The following is a description of a gene set: species: Homo sapiens Genes down-regulated in peripheral blood mononuclear cell 192h vs 0h in adults (22-54) after exposure to F. tularensis vaccine LVS, time point 192H from publication Fuller CL, Brittingham KC, Porter MW, Hepburn MJ, Petitt PL, Pittman PR, Bavari S (PMID 17349694) Human Gene Set: FULLER_PBMC_F_TULARENSIS_VACCINE_LVS_AGE_22_54YO_192HR_DN The live vaccine strain (LVS) of Francisella tularensis is the only vaccine against tularemia available for humans, yet its mechanism of protection remains unclear. We probed human immunological responses to LVS vaccination with transcriptome analysis using PBMC samples from volunteers at time points pre- and post-vaccination. Gene modulation was highly uniform across all time points, implying commonality of vaccine responses. Principal components analysis revealed three highly distinct principal groupings: pre-vaccination (-144 h), early (+18 and +48 h), and late post-vaccination (+192 and +336 h). The most significant changes in gene expression occurred at early post-vaccination time points (<=48h), specifically in the induction of pro-inflammatory and innate immunity-related genes. Evidence supporting modulation of innate effector function, specifically antigen processing and presentation by dendritic cells, was especially apparent. Our data indicate that the LVS strain of F. tularensis invokes a strong early response upon vaccination. This pattern of gene regulation may provide insightful information regarding both vaccine efficacy and immunopathogenesis that may provide insight into infection with virulent strains of F. tularensis. Additionally, we obtained valuable information that should prove useful in evaluation of vaccine lots as well as efficacy testing of new anti-F. tularensis vaccines., and this is the list of marker genes: DCSTAMP, CCL17, CD74, CD68, LAMP3, FCER1G, FCER1A, CCR7, CD209, FCGR2B, CD58, CCR6, CD44, HSP90B1, FCGR3A, CDC42, CCL19, CCR1, CCR3 (NCBI Gene Id 1232), CCL20, FAS, TAP2, ICAM1, FCGR2A, B2M, IRAK1, CD80, TICAM1, CCL18, PYCARD, CD83, SOD2, ICOS